Given this list of marker genes Fundc1, Vdac3, Rps27a, Gabarapl2, Tomm7 (NCBI Gene Id 66169), Tuba8, Tubal3, Ube2n, Park7, Optn, Atg16l2, Uvrag, Atg7, Sqstm1 (sequestosome 1), Rraga, Tomm5, Pink1, Atg9b, Tomm20, Dynll1, Tsc1, Csnk2b, Chmp2a, Chmp2b, Atg3, Rheb, Ube2v1, Tomm6, Cetn1, Vim, Rragc, Gabarap, Tubb4a, Tomm22, Ulk1, Mtmr14, Pex5, Tuba4a, Vdac1, Prkag3 (protein kinase, AMP-activated, gamma 3 non-catalytic subunit), Lamtor2, Ubb, Mtmr3, Pik3c3, Tuba1c, Prkag1, Ift88, Atg12, Atg4d, Prkn, Tubb4b, Tuba1b, Becn1, Atg4c (NCBI Gene Id 242557), Pgam5, Tuba3b, Tubb6, Wdr45b, Map1lc3b (NCBI Gene Id 67443), Lamtor5, Tubb2b, Vdac2, Atg101, Tuba1a, Lamtor4, Nbr1, Dync1li2, Mterf3, Mfn2, Lamtor1, here is a description of the gene set: electronically inferred by orthology from the curated human pathway Reactome Pathway: Autophagy studied in species Mus musculus This event has been computationally inferred from an event that has been demonstrated in another species.<p>The inference is based on the homology mapping from PANTHER. Briefly, reactions for which all involved PhysicalEntities (in input, output and catalyst) have a mapped orthologue/paralogue (for complexes at least 75% of components must have a mapping) are inferred to the other species.